The following is a description of a gene set: Reactome Pathway: Signal regulatory protein family interactions part of: Cell-Cell communication species: Homo sapiens Signal regulatory protein alpha (SIRPA, SHPS1, CD172a) is a transmembrane protein expressed mostly on myeloid cells. CD47, a widely expressed transmembrane protein, is a ligand for SIRP alpha, with the two proteins constituting a cell-cell communication system. The interaction of SIRPA with CD47 is important for the regulation of migration and phagocytosis. SIRPA functions as a docking protein to recruit and activate PTPN6 (SHP-1) or PTPN11 (SHP-2) at the cell membrane in response to extracellular stimuli. SIRPA also binds other intracellular proteins including the adaptor molecules Src kinase-associated protein (SKAP2 SKAP55hom/R), Fyn-binding protein/SLP-76-associated phosphoprotein (FYB/SLAP-130) and the tyrosine kinase PYK2. SIRPA also binds the extracellular proteins, surfactant-A (SP-A) and surfactant-D (SP-D). <br>The SIRP family members SIRPB and SIRPG show high sequence similarity and similar extracellular structural topology, including three Ig domains, but their ligand binding topology might differ. SIRPB is expressed on myeloid cells, including monocytes, granulocytes and DCs. It has no known natural ligand. SIRPG can bind CD47 but with lower affinity than SIRPA., and this is the list of marker genes: GRB2, PTPN11, SRC, SKAP2, PTK2B, SFTPA1, SFTPA2, SIRPG, CD47 (CD47 molecule), SIRPA, PTK2, TYROBP, SFTPD, SIRPB1, PTPN6, FYB1